The following is a description of a gene set: Human Gene Set: GSE2770_IL12_VS_IL4_TREATED_ACT_CD4_TCELL_6H_UP studied in species Homo sapiens from publication Lund R, Aittokallio T, Nevalainen O, Lahesmaa R (PMID 14607935) Genes up-regulated in CD4 T cells activated by anti-CD3 and anti-CD28: IL-12 (6h) versus IL4 (6h). Th1 and Th2 cells arise from a common precursor cell in response to triggering through the TCR and cytokine receptors for IL-12 or IL-4. This leads to activation of complex signaling pathways, which are not known in detail. Disturbances in the balance between type 1 and type 2 responses can lead to certain immune-mediated diseases. Thus, it is important to understand how Th1 and Th2 cells are generated. To clarify the mechanisms as to how IL-12 and IL-4 induce Th1 and Th2 differentiation and how TGF-beta can inhibit this process, we have used oligonucleotide arrays to examine the early polarization of Th1 and Th2 cells in the presence and absence of TGF-beta after 0, 2, 6 and 48 hours of polarization., and this is the list of marker genes: H2AJ, CCDC117, FABP5, ITIH3, RUVBL2, PDX1 (pancreatic and duodenal homeobox 1), ZBTB17, YARS1, DNPEP, NHERF1, CRYBB2, SEC61A2, PARK7, ZAP70, KRT2, ACTL7B, CSRP1, HTR1B, RNF207, GPR37, MRPL11, FOXL2, ABI1 (NCBI Gene Id 10006), AFF1, CA1, ADGRA3, PLEKHH1, NAALAD2, GCK, ADAMTSL3, P2RY13, ACAP3, WDR41, SNTA1, DMRT3, ZNF790, USP39, FAM120A, RNASE6, ARL4D, WDR4, NYX, PRRT4, FLOT2, ARF6, MCMBP, GFRA3, BMP1, IHH, TUBA4A (tubulin alpha 4a), OXSR1, PIWIL2, PAX7, DPCD, GULP1, B3GAT1, COMMD5, PIGO, FNTA, PIGH, CHFR, SMCO4, ZBTB10, TRAM1, PPOX, UQCC1, ERN2, SORD, SLC25A19, XRCC2, CYS1, GSK3A, GPI, CYSLTR1, FAM193A, KCTD20, SCARF1, KDM4A, CMTM6, RAB11FIP1, DRC12, KXD1, TOMM70, MAPK10, CNDP2, HDDC3, CASQ2, CES4A, IFT74, DHFR, THBD, SOST, PSD, DRG1, FTMT, PHYHD1 (phytanoyl-CoA dioxygenase domain containing 1), FSD2, COMMD1, BARX2, SIK1, ACCS, OXNAD1, PRR18, GRWD1, CRADD, GTF2H3, PTPRG, NSD2, RNASEH2A, AIRIM, AGAP2, BRMS1, DUS1L, FKBP1A, MLYCD, RNPS1, ATG10, ATL2, SFXN2, HS3ST2, NPHP1, ZNF546, SMIM7, RHAG, MYL10, AJM1, CLCN5, AEBP1, SPATS2L, C1orf74, CUL7, YIPF7, STRA8, KCNC2, SMOC2, YBX3, CAMK2A, PLEKHA7, TXNDC11, PEX16, GPX4, UBE2M (NCBI Gene Id 9040), IL17RD, PLCD3, RLF, ERGIC3, PELI2, ANAPC16, ADGRD1 (NCBI Gene Id 283383), KCP, DDX21, TIMM8A (NCBI Gene Id 84782), KDR (NCBI Gene Id 3791), MTSS1, STX1A, SATB1, ZFP37, CCND2, AMN, MRPS24, CYSRT1, TCF4, POLD1, SIX6, IL1RAPL2, VIPAS39, NAT14, SNAP91, BTF3, MUC4, PARD6G, TOMM20, INKA1, YTHDF1, PSMA3, CUZD1, NSDHL, ADAMTS18, MID2, RBM10, TTYH2, PPP2R5E (protein phosphatase 2 regulatory subunit B'epsilon), TBC1D17, LENG9, SLC44A2, CRYZ, TRIM25, DHX58, COL15A1, CLCA2, PITPNM1, PUS3, CHAF1B, MAP1LC3B, MPL, CCL22, TCAF1, OAZ1, TIMM22, UNC45A